Given this list of marker genes Btbd9, Vamp4, Nrxn1, Rph3al, Rab3a, Kcnh1, Prepl, Pcdh17, Pclo, Syt5, Atp6v0c, Nlgn3, Cxadr, Fbxl20, Ap2a2, Park7, Cyfip1, Dnajc6, Cplx4, Pacsin1, Snapin, Npy1r, Syt9, Pld1, Dnm1l, Lpar1, Rapgef4, Casp3, Atp6v1h, Atp2a2, Unc13c, Stx1b, Wnt7a, Syngr3 (NCBI Gene Id 20974), Tprg1l, Atp6v0d1, Ston1, Slc18a3, P2ry2, Th, Atp6v1g1, Scrib, Stxbp5l, Cadps2, Prkcb (NCBI Gene Id 319718), Ap3d1, Dvl1, Sv2b, Rab27b, Syt2, Nlgn2 (NCBI Gene Id 216856), Fbxo45, Itsn1, Cplx2, Canx, Snap91, Cplx3 (complexin 3), Cspg5, Syde1, Prkn, Stx1a, Syt12, Ddc, C9orf72, Atp6v1e1, Git2, Ap3s2, Rimbp2, Otof, P2rx7, Snap29, Cltc, Prrt2, Stxbp5, Bin1, Prkar1b, Doc2a, Rap1a, Atp6v1g2, Vamp2, Rab3gap1, Cacna1b, Cdk5, Snap23, Plaa, Vps18, Ap3s1, P2ry1, Sh3gl1, Syn3, Sncb, Htr1d, Btbd8, Arpc3, Syt11, Sgip1, Cdk5r1, Snap47, Ppfia3, Cplx1, Cadps, Syn2 (synapsin II), Fmr1, Htr1b, Atp6v1c1, Syndig1, Scrn1, Erc2, Slc18a2, Sncg, Syp, Trim9, Dennd1a, Rap1b, Rab3b, Slc17a5, Bltp1, Synj2, Git1, Dnm2, Sh3gl2, Syt8, Magi2, Ctbp2, Doc2b, Unc13b, Gpr151, Pik3c3, Atp6v1d, Cdh2, Arf6, Rims2, Ap1s2, Ap2b1, Rims3 (NCBI Gene Id 279225), Diaph1, Ap2s1, Mx2, Actb, Clcn3, Atp6ap2, Erc1, Rab7, Tbc1d24, Atp8a1, Nlgn1, Ophn1, Dgkq, Arhgdia, Slc2a4, Doc2g, Itsn2, Snx9, Vamp1, Actg1, Ppfia2, Ap2a1, Amph, Pfn2, Stx19, Stx11, Syn1, Grn, Prkcg, Rims4, Ctbp1, Ppp3cc (NCBI Gene Id 19057), Ncs1, Stxbp1, Syt10 (NCBI Gene Id 54526), Atp6v1b1, Myo5b, Slc4a8, Ston2, Braf, Stx4a, Bcl2l1, Pip5k1c, Slc10a4, Snca, Sv2c, Kcnc3, Rims1, Atp6v1a, Syt1, Slc18a1, Scamp5 (NCBI Gene Id 56807), Unc13a, Ppp3cb, Tor1a, Cacna1e, Gripap1, Cacnb4, Atp6v0a1, Slc17a8, Septin5, Bsn, Abca13, Sv2a, Syt7, Atp6v1f, Dnajc5, Cacna1a, Syt4, Atg7, P2ry4, Npy, Atp6v1g3, Fgf14, Napb, P2rx2, Cltb, Cacna1d, Rock1, Mff, Lrrk2, Ctnnb1, Ap3b2, Snap25, P2rx1, Slc32a1, Slc17a6, Dtnbp1, Cd24a, Rph3a, Stxbp2, Camk2a, Picalm, Prkca, Syt13, Dnm3, Pten, Ap2m1, Sptbn2, Ppp3r1, Rac1, Brsk1, Cask, Ap3m2, Fcho2, Stx2 (syntaxin 2), Slc9a6, Atp6v0e2, Psen1, Pls3, Prkaca, Atp6ap1, Rab5a, Napa, Slc17a7, Atp6v1b2, Efr3a, Stxbp3, Dnm1, Synj1, Atp6v0a4, Osbpl2, Eps15l1, Capn2, Grik5, here is a description of the gene set: species: Mus musculus Mouse Gene Set: GOBP_SYNAPTIC_VESICLE_CYCLE A biological process in which synaptic vesicles are loaded with neurotransmitters, move to the active zone, exocytose and are then recycled via endocytosis, ultimately leading to reloading with neurotransmitters.